The following is a description of a gene set: Genes predicted to be targets of miRBase v22 microRNA hsa-miR-6734-3p in miRDB v6.0 with MirTarget v4 prediction scores > 80 (high confidence targets). studied in species Homo sapiens from publication Chen Y, Wang X (PMID 31504780) Human Gene Set: MIR6734_3P, and this is the list of marker genes: DGKG, LSAMP, THBS1, GPR26, AGO1, DNAJC21, ENTREP1, ARF6, TOR1B, IFFO2, DLAT, ARHGAP17, RNLS, HTT, GALNT6, PLCXD3, EPHB1, TJP1, WDR45B, RASSF10, STYX, AQR, DQX1, CCDC182, FAM53C (family with sequence similarity 53 member C), DLG5, TSC1, RBPJ, CAMK1D, RORB, SPATS2L, GMEB1, VANGL1, CRY2, ZNF511, ERMP1, RNF215, KHNYN, CTCF, LPIN3, CREB1, APH1A, NFE2L1, ZCCHC18, C1orf74, DOLPP1, CBX1, TFE3, PROX2, PARP1, KDM4C, KDM3B, MLEC, PCP4L1, NCSTN, KAT7, AP1G1, ANKS1A, TMEM260, ADCY1, TNRC18, ATXN1, ZNF584, ASPH, CTDSP1, LRIF1, GLIPR2, PCYT1B, H6PD, PTCD3, HES2, NCR3, TNRC6B, GPR52 (NCBI Gene Id 9293), RB1, RAP1B, CARM1 (NCBI Gene Id 10498), KALRN, ZNF781, CXCR5, PRCD, DESI1, DOCK5, EIF4EBP2, RBM33, RIMS4, SLC6A17, PIM2 (Pim-2 proto-oncogene, serine/threonine kinase), BRPF3, HRAS, UNKL, ADGRF5, LYRM7, AK4, PPP4R3A, AGPS, PRKAA2, L2HGDH, LEP, EPHB2 (NCBI Gene Id 50980), RCOR1, GGA1, PRDM4, NAV1, FFAR4, TBL1X, CHST11, FIGNL2, TBC1D16, GPR55, CBLL1, TTC39B, SMCR8, RAB7A, RBM15B, ZNF827, SIRPA, EOLA1, ADORA2A, RAB11FIP4, ZNF559-ZNF177, TMEM178B, CCDC85C, HIF1AN, NCOR2, RMND5A, CDK14 (NCBI Gene Id 5218), POU2F2, MORC2, SCIMP, NECAP2, UNC5D, POLR1A (RNA polymerase I subunit A), SNX1, GFI1, GABBR1, LARS2, CACNB3, LIPH (lipase H), SYT2, KLHDC7A, GPR161